The following is a description of a gene set: species: Mus musculus Mouse Gene Set: CUI_CDC2_IL17B_RESPONSE_UP Genes positively differentially expressed in cell type: cDC2 (conventional dendritic cell type 2) upon treatment with cytokine: IL-17B in mouse lymph nodes in vivo. from publication Cui A, Huang T, Li S, Ma A, Pérez JL, Sander C, Keskin DB, Wu CJ, Fraenkel E, Hacohen N (PMID 38057668) Cytokines mediate cell-cell communication in the immune system and represent important therapeutic targets. A myriad of studies have highlighted their central role in immune function, yet we lack a global view of the cellular responses of each immune cell type to each cytokine. To address this gap, the authors created the Immune Dictionary, a compendium of single-cell transcriptomic profiles of more than 17 immune cell types in response to each of 86 cytokines (>1,400 cytokine-cell type combinations) in mouse lymph nodes in vivo. A cytokine-centric view of the dictionary revealed that most cytokines induce highly cell-type-specific responses. For example, the inflammatory cytokine interleukin-1β induces distinct gene programmes in almost every cell type. A cell-type-centric view of the dictionary identified more than 66 cytokine-driven cellular polarization states across immune cell types, including previously uncharacterized states such as an interleukin-18-induced polyfunctional natural killer cell state., and this is the list of marker genes: Srd5a3, Ass1, Tmed7, Pcyt1a, Brd4, Slc30a4, Eif4e, Ruvbl1